The following is a description of a gene set: Genes up-regulated in invasive ductal carcinoma (IDC) relative to ductal carcinoma in situ (DCIS, non-invasive). species: Homo sapiens Becoming invasive is a crucial step in breast cancer oncogenesis. At this point, a lesion carries the potential for spreading and metastasis--a process, whose molecular characteristics still remain poorly understood. In this article, we describe a matched-pair analysis of ductal carcinoma in situ (DCIS) and invasive ductal carcinoma (IDC) of nine breast ductal carcinomas to identify novel molecular markers characterizing the transition from DCIS to IDC. The purpose of this study was to better understand the molecular biology of this transition and to identify candidate genes whose products might serve as prognostic markers and/or as molecular targets for treatment. To obtain cellular-based gene expression profiles from epithelial tumor cells, we combined laser capture microdissection with a T7-based two-round RNA amplification and Affymetrix oligonucleotide microarray analysis. Altogether, a set of 24 tumor samples was analyzed, comprised of nine matched DCIS/IDC and replicate DCIS/IDC preparations from three of the nine tumors. Cluster analysis on expression data shows the robustness and reproducibility of the techniques we established. Using multiple statistical methods, 546 significantly differentially expressed probe sets were identified. Eighteen candidate genes were evaluated by RT-PCR. Examples of genes already known to be associated with breast cancer invasion are BPAG1, LRRC15, MMP11, and PLAU. The expression of BPAG1, DACT1, GREM1, MEF2C, SART2, and TNFAIP6 was localized to epithelial tumor cells by in situ hybridization and/or immunohistochemistry, confirming the accuracy of laser capture microdissection sampling and microarray analysis. Human Gene Set: SCHUETZ_BREAST_CANCER_DUCTAL_INVASIVE_UP from publication Schuetz CS, Bonin M, Clare SE, Nieselt K, Sotlar K, Walter M, Fehm T, Solomayer E, Riess O, Wallwiener D, Kurek R, Neubauer HJ (PMID 16707453), and this is the list of marker genes: PDE10A (phosphodiesterase 10A), COL5A1, ANXA1, PTEN, OLFML3, ETV1, RECK, OLFML1, ANKRD6, DPYD, SCG5, ACSL4, TGFBI (transforming growth factor beta induced), GPX7, SHOX2, KDR, SERPING1, MEF2C, NOX4, MAP4K4, TGFB1I1, AHNAK2, COL1A1, NBL1, TUBB6, TMEM47, COL6A2, BGN, LOXL2, MERTK, PLSCR4, SPARCL1, WWTR1, SAMD4A, DPYSL3, CH25H, C1S, RCBTB2, KCND2, RNASE6, SSPN, F2R, CPA3, GPR65, CCN1, TFEC, LOXL1, HLA-DMB, TDO2, TLR7 (toll like receptor 7), KCNJ2, TRIM22, S100A4, CD163, NID2, SOBP, FLI1, ANGPTL2, PLXNC1, IFFO1, SGK1, CDH11 (cadherin 11), NUAK1, FYN, TYROBP, ALOX5, MXRA8, THSD7A, GRK5, ARL4C, GFPT2, LAPTM5, MXRA7, SMAD7, PDGFRB, CD55, EVI2B, LOX, IGFBP7, THY1, AKR1B1 (aldo-keto reductase family 1 member B), LMO2, LAMA4, MS4A6A, COL11A1, TMEFF1, SPOCK1, PLAU, CPQ, FCGR2A, PMEPA1, ROR1, INHBA, ENTPD1, TGFBR2, LAMC1, GLIPR1, VCAN, P2RY14, CTSS, FCGR1A, COL4A2, EMP3, PTPRC (protein tyrosine phosphatase receptor type C), JAM3, COL8A2, HMOX1, SPON2, BICC1, HLA-DQA1, ST3GAL6, WIPF1, MMP1, FGL2, GPNMB, ADGRL4, CLEC11A, SLC9A6 (solute carrier family 9 member A6), COPZ2, PLCG2, HCLS1, PECAM1, NID1, TCF4, COL1A2, MEIS2, ARHGEF40, LDLRAD4, MRC2, GREM1, LHFPL6, COL16A1 (NCBI Gene Id 1307), ATP10D, PRNP, TMEM204, ITGBL1, CFH, TRDC, MMP13, MMP2, MSR1, FSTL1, SLC2A3, CD93, THBS2 (thrombospondin 2), GIMAP4, ASPN, DACT1, COL6A1, CAVIN3, MMP11, POSTN (periostin), TP53I3, FCGR3B, DAB2, PRRX1, GAS1 (NCBI Gene Id 2619), DPY19L1, FTL, AEBP1, HSD17B6, ELK3, EMP1, FZD2, DCN, SLAMF8, CPVL, CLEC7A, C1QB, PDLIM2, FERMT2, PLN, MS4A4A, EML1, PROS1, LDB2, CLEC2B, COL10A1, LUM, ZEB1, HLA-DMA, IFI30, TM6SF1, HTRA1, MICAL2, LYN, SEPTIN6, MSN, GLS, LGALS1, CLEC4A, HLA-DRB6, FXYD5, TNFSF4, GLRX, PTPRM (NCBI Gene Id 5797), GIMAP6, MYL9, HLA-DQB1, TMEM158, SERPINE2, LAMB1, SEPTIN11, PKD2 (NCBI Gene Id 5311), KCTD12, NDN, SPARC, LRRC17, HEY1, IGLC2, SKAP2, APOE, CCN2 (NCBI Gene Id 1490), TNFAIP6, PLAUR, ADORA3, COL4A1, PPIC, LPXN, LRRC15, FN1, LCP2, SPHK1, COL5A2, CALD1, CCL5, HTR2B, SDC2, C1QA, CCND2, ADAM12, IRF8, FAP, ECM2, MFAP5, NRP1, TWIST1, PLS3, QKI, ISLR, SMCO4, RGS1, SEC23A, PDGFRA, HSD17B11, LY96, ROBO1, CTSK, ZFPM2, ENPEP, PALLD, JCAD, CD74, MAFB (NCBI Gene Id 9935), FBLN2, C1R, ERG, DNM3, HEG1, ACKR3, GBP1, HLA-DRB1, HLA-DQB2, OLFML2B, IFI16, ADGRF5 (NCBI Gene Id 23282), IGFBP3, RGS2, COMP, IRAK3, SERPINH1, ZEB2, MXRA5, COL6A3, TIMP3, FOXN3, CASP1, LMCD1, NREP, CILP, TLE4, COL3A1, AXL, MNDA, EDNRA, SRGN, HLA-DPA1, TGM2, CEMIP, RGCC, TRPC1 (transient receptor potential cation channel subfamily C member 1), CCN4 (cellular communication network factor 4), MME, IL18, OLR1, TACC1, CAVIN1, AKT3 (NCBI Gene Id 26068), FBN2, ADAM19, COLEC12, COL15A1 (collagen type XV alpha 1 chain), SGCD, IL1R1, CELF2, SAMSN1, MAP1B, XYLT1, SRPX2, HLA-DPB1, SGCB, C3AR1, RASSF2, HLA-DRB4, CD53, EFEMP2, SNAI2, MAF, PAM, HPGDS, PARVA, RARRES2, ESM1, CCR1, ADCY7, RCAN2, COL14A1, DSE, PSMB9, CSF2RB, PLXDC1, FAS, CRISPLD2, EVI2A, SLC16A3, MMP3, GEM, SLC7A7, TNS3, RGS4, SPON1, FCER1G (Fc epsilon receptor Ig), C1orf54, MFAP2, FKBP11, SERPINF1, FBN1, ETV5, ABCC4, NNMT, SULF1, HLA-DRA